Given this list of marker genes RUNX1, BCL6, FOXP3, HMGB1, STAT5A, SMAD7, SHH, TNFSF4, GLI3, ZC3H12A, HLX, ZBTB7B, ANXA1, RC3H1, RUNX3, IL2, RC3H2, CBFB, SOCS5, TBX21, SLC4A2, JAK3 (Janus kinase 3), CD69, TNFSF18, IHH, SOCS1, ASCL2, LOXL3, IL4R, LGALS1, here is a description of the gene set: studied in species Homo sapiens Any process that stops, prevents, or reduces the frequency, rate or extent of alpha-beta T cell differentiation. Human Gene Set: GOBP_NEGATIVE_REGULATION_OF_ALPHA_BETA_T_CELL_DIFFERENTIATION